The following is a description of a gene set: studied in species Mus musculus Mouse Gene Set: GOBP_RESPONSE_TO_NEMATODE Any process that results in a change in state or activity of a cell or an organism (in terms of movement, secretion, enzyme production, gene expression, etc.) as a result of a stimulus from a nematode., and this is the list of marker genes: Retnla, Il25, Il13, Hpgds, Ptger2, Cyp1a1, Lilrb4a, Arg1, Itln1, Chil3, Ptger4, Ptgs2, Il4, Rbbp9